The following is a description of a gene set: studied in species Homo sapiens Genes down-regulated in lymphoid primed multipotent progenitors versus granulocyte-monocyte progenitors. Expression profiling of Rag2-deficient Ets1++ and Rag2-deficient Ets1-- mature NK cells and WT bone marrow progenitors, WT T cells, and WT Pro B cells Human Gene Set: GSE37301_LYMPHOID_PRIMED_MPP_VS_GRAN_MONO_PROGENITOR_DN from publication Ramirez K, Chandler KJ, Spaulding C, Zandi S, Sigvardsson M, Graves BJ, Kee BL (PMID 22608498), and this is the list of marker genes: GPAA1, MDC1, ZNF518A, E2F1, ATP5IF1, PHC1, TCTA, PIGN, DYSF, RMI1 (NCBI Gene Id 80010), SOCS2, ETV4, FAM89B, LY6E, ROCK1, ZMAT5, GNAI2, AKT1, PPM1D, YAF2, GAS2L1, PXMP2, BFAR, ALOX5AP, SEPTIN9, CTCF, NOTCH2, PHTF2, ABCC10, HPS6, MED16, ZNF217, INPP4A, FKBP2, TOM1, INPP5E, USP20, VOPP1, ERP29, MRFAP1L1, TST, EFCAB11, RNF170, TMEM59, INTS3, HPS1, CKLF, ARL2, TSPYL1, OSTM1, ZBTB38, KCTD5, LGALS3BP, CEACAM1, ENSG00000289047, FRAT1, PHF20, WWP2, MYBL1, CHEK1, SNRK, PARP4, DNMT1, TNRC6B, PCMTD2, RCC1L, WDR37, PPP2R5A, ZNHIT1, MRPL34, STAG1, UBA3, PAFAH1B3, IGKV3-20, SEPHS2, FLOT1 (NCBI Gene Id 10211), DMTN, KAT7, PDGFD, SH3BP1, HOXD13, QRICH1, LAMTOR2, WWC3, TACC1, FEZ2, ASPSCR1, EXOC1, GLB1, NUP50, NCAM1, UBE2I, RUSC1, NXT2, STAP1, FGGY, ZMIZ1, SH3GL1, MARF1, ASTE1, PRKCI, ARAP3, YIPF1, CUL2, OAS1, HINT1, TMEM41B, LEPROTL1, LBHD1, ST3GAL5, PPT1, CASP9, IFT25, GLYR1, RASSF1, NDUFS1, ANKZF1, DLGAP5, RUBCN, SLFN12, ZDHHC3, CD101, LPIN2, MX2, RAP1GDS1, ERCC3, PIGG, C2CD2, ACOT8, SOS1, SQOR, RANBP6, KIFAP3, VPS51, FAIM, SNAPC3, AP2A2, ANKRD36B, CDK19, TM7SF3, WWOX, PRG2, DPP8, PLAAT3, SUMO2, ATAD5, HAUS5, INPP5A, FBXL4, SC5D, PBLD, FAH, ADIPOR2, GET1, ARPC3, CEP68, E2F3, ABHD17A, CASP8AP2, ZMYM6, CDC7, ARPC5, CSNK1G2 (casein kinase 1 gamma 2), SHFL, PAQR4, MSANTD2, HERC2, SLC33A1, AP3S1, CHAF1A, RWDD3, MPHOSPH9, CZIB, TNFSF13, TRIM68, TRIM26, MKRN1, CMC4, RIPOR1, AMDHD2, ATP2A3, SCCPDH, ACYP2, ZFP64, TMEM168, OARD1, RABGAP1, DENND2D, MTMR1, DHCR24, ABI2, HSD17B7, TMSB15B, CCDC92, AAMDC, MAN2B1, USP21, IL2RG, KDM5A